Given this list of marker genes HOXA13, HNF1B, HIF1A, PAX8, TBX1, POU3F4, EDNRA, PAX2, SHH, BMP7, MSX1, GDF5, SOX9, MSX2, ETV6, here is a description of the gene set: Human Gene Set: GOBP_MESENCHYMAL_CELL_APOPTOTIC_PROCESS studied in species Homo sapiens Any apoptotic process in a mesenchymal cell. A mesenchymal cell is a loosely associated cell that is part of the connective tissue in an organism. Mesenchymal cells give rise to more mature connective tissue cell types.